The following is a description of a gene set: studied in species Homo sapiens part of: Cell Cycle Checkpoints Reactome Pathway: G1/S DNA Damage Checkpoints When a DNA damage occurs during G1 phase of the cell cycle, it activates a G1/S DNA damage checkpoint that pauses the cell cycle to allow time for DNA repair. In the G1 phase there are two types of DNA damage responses, the p53-dependent and the p53-independent pathways. The p53-dependent responses inhibit CDKs through the upregulation of genes encoding cyclin-dependent kinase inhibitors (CKIs) mediated by the TP53 transcription factor, whereas the p53-independent mechanisms inhibit CDKs through the inhibitory T14 and Y15 phosphorylation of CDK2. Failure of DNA damage checkpoints in G1 leads to mutagenic replication of damaged templates and other replication defects., and this is the list of marker genes: MDM2, CCNA2, PSMB1, CDKN1A, MDM4, CDC25A, MAPK14, PSMC6, PSMB3, TP53, PSMB7, PSMC2, PSMD12, PSMD3, UBC, ADRM1, RBX1, PSMA6, GSK3B, BTRC, CDKN1B, PSMA1, COP1, PSMB5, PSMA5, CCNA1, PSMC4, PSMD11, PCBP4, CDK2, UBA52, CSNK1E, PSMA3, PSMD13, NEK11, PSMD6 (proteasome 26S subunit, non-ATPase 6), SEM1, PSMB6, PSMA7, CUL1, CSNK1A1, RPS27A, SKP1, CDKN2A, CCNE2, ZNF385A, PSMD8, CHEK2, CHEK1, PSMB2, PSMC3 (proteasome 26S subunit, ATPase 3), PSMD14, PSMB4, PSMC1, ATM, CCNE1, FBXW11, PSMA2, PSMC5, PSMD2, MAPK11, PSMD1, PSMD7 (proteasome 26S subunit, non-ATPase 7), PHF20, UBB, PSMA4, PLK3